The following is a description of a gene set: Shortening of the poly(A) tail of a nuclear-transcribed mRNA from full length to an oligo(A) length. Mouse Gene Set: GOBP_NUCLEAR_TRANSCRIBED_MRNA_POLY_A_TAIL_SHORTENING studied in species Mus musculus, and this is the list of marker genes: Mlh1 (NCBI Gene Id 68687), Tent4b, Zfp36, Samd4b, Pabpc1, Pnldc1, Cnot1, Cnot7, Zfp36l3, Cnot2, Tob1, Ago2, Samd4, Btg2, Tnrc6c, Tnrc6b, Tent4a, Cnot3, Eif4enif1, Polr2g, Pan3, Pan2, Tnrc6a, Parn, Cpeb3, Cnot6